The following is a description of a gene set: The series of molecular signals initiated by interleukin-10 binding to its receptor on the surface of a target cell, and ending with the regulation of a downstream cellular process, e.g. transcription. studied in species Mus musculus Mouse Gene Set: GOBP_INTERLEUKIN_10_MEDIATED_SIGNALING_PATHWAY, and this is the list of marker genes: Il10, Il10ra, Jak1, Stat3, Il10rb, Tyk2